Given this list of marker genes DHDDS, NUS1, DHRSX, DOLK, SRD5A3, MVD, DOLPP1, here is a description of the gene set: part of: Synthesis of substrates in N-glycan biosythesis species: Homo sapiens Dolichol is a polyisoprenol lipid comprised of five-carbon isoprene units linked linearly in a head-to-tail fashion. Almost all eukaryotic membranes contain dolichol and its phosphorylated form is used in the N-glycosylation of proteins where it is used as an anchor for the N-glycan sugar to the ER membrane, and as an initiation point for the synthesis. Dolichol biosynthesis occurs on the cytoplasmic face of the ER membrane, which is where N-glycosylation occurs too, so is perfectly placed to serve as a substrate for this process. Dolichyl phosphate can be obtained either from direct phosphorylation of dolichol, formed in a series of reactions from mevalonate 5-pyrophosphate, or a salvage reaction by de-phosphorylation of dolichyl diphosphate, released at the end of N-glycan biosynthesis (Cantagrel & Lefeber 2011). Reactome Pathway: Synthesis of dolichyl-phosphate